Given this list of marker genes ADM (adrenomedullin), TTR, GUCY2C, DDC, ACHE, GUCY2D, DIO1, GUCY1B1, GUCY1A2, NPR1, GUCY2F, GAD2, ADCY8 (adenylate cyclase 8), MAOA, NPR2, here is a description of the gene set: Human Gene Set: MODULE_445 Genes in the cancer module 445. studied in species Homo sapiens